The following is a description of a gene set: species: Homo sapiens Human Gene Set: GOBP_MUSCLE_TISSUE_DEVELOPMENT The progression of muscle tissue over time, from its initial formation to its mature state. Muscle tissue is a contractile tissue made up of actin and myosin fibers., and this is the list of marker genes: MSTN, MYOM1 (NCBI Gene Id 8736), CCNT2, ABL1, CDK1, BCL9L, MIR548C, ITGB1, GREB1L, FGF8, KLF5, FGF20, MYL6, MEF2A, PPP3CB, ZMPSTE24, TTN, EFEMP2, POGLUT1, LUC7L, FOXP2, ALPK3, BVES, PIM1, TSC1, NPR2, LEMD2, MIR19B1, GSK3A, EP300, MYOCD, KAT8, TGFB1 (NCBI Gene Id 7040), MYF6, NPPB, PLEC, SMAD4, JPH2, KDM6B, MIR19A, PRKG1, TGFBR3, COL14A1, SOX6, FHL2, GPX1 (NCBI Gene Id 2876), FOS, NPRL3, FKBP1A, PROX1, FOXN2, CAV3, FGF2, CCNB1 (NCBI Gene Id 891), CHRND, MIR23A, KRAS, PITX2, GREM1, CSRP3, ADAMTS9, MCUB, MSX2, VGLL4, ZFPM1, ALPK2, MBD2, MYOZ2, ATG5, ISL1, MED1, EGLN1, AKAP13, RXRB, MEF2C, PPP1R13L, CDK5, PKD2 (polycystin 2, transient receptor potential cation channel), TCAP, CHRNA1, CALR, FGFR2, SVIL (NCBI Gene Id 6840), TREX1, MIR24-1, ATF3, KCNJ8, BARX2, KEL, DMRTA2, MYH15, NOG, NOX4, NOTCH2, FGFR1, HMG20B, HLF, NR2F2, CACNA1G, KLHL40, PAX7, FZD7, MYOZ1, MIR208A, PAX5, FLOT1 (NCBI Gene Id 10211), MYH14, VAMP5, SELENON, TBX5, MIR222, IGF2, TCF21, MYL11, CNTNAP1, FGF9, COL11A1, DDX5, WNT10B (NCBI Gene Id 82499), IFRD1, RBM24 (RNA binding motif protein 24), MIR1-1, FRS2, MSC, GLI1, PRMT1, WNT3A, HSD17B1, MYORG, SMAD1, RYR1, FOSL2, VAX1, MAPK14 (mitogen-activated protein kinase 14), NUPR1, TENM4, AKAP6, RHOA, CACYBP (calcyclin binding protein, NCBI Gene Id 27101), TNNI1, PHOX2B, TLL2, MIR195, PGM5, BMPR1A, PAK1 (p21 (RAC1) activated kinase 1), ACTA1, HLX, SLC8A1, RARB, ADRA1A, RBP4, NR4A1, EDNRA, ACTC1, RYR2, YY1, MYLK3, MIR873, G6PD, UQCC2, TBX2, GATA4, RGS4, BMPR2, MYBPC3, MYLK2, MIR145, TBX18, NOTCH1, WT1, CASQ1, MYO18B, COPS2, ACVR1, MYL6B, TGFB2, DSP, CHD7, MYC, SOX8 (SRY-box transcription factor 8), IRX3, HEY1, PI16, OSR1, B4GALNT2, HAND1, SKIL, SKI, MIR509-1, SGCD, DNER, VEGFA, FOXL2, HOXD10, NR1D2, TIPARP, MIR143, MYF5, CTNNB1, MYLK, MED20, PDLIM5, ERBB4, PARP2, RBPJ, MIR204, CAV2, PLN, FOXC1, ASB2, COL6A1, SHH, ANKRD1, GATA5, STRA6, NKX2-5, LRRC10, CDC42, CENPF, NDRG4, SGCG, MYH6, MYL2, EYA2, KCNJ11, ANHX, MYH11, NAGLU, CYP26B1, PKP2, POPDC3 (popeye domain containing 3), CTDP1, DMD, BCL2, ABCC9, CTCF, CACNA1S, SGCZ, TPM1 (tropomyosin 1), PPP3CA, DDX17, HEG1, YBX3, EFNB2, CREB1, CDON, HCN4, RARA, SAP30, MTPN, SIK1, SORBS2, HEYL, IFT20, SIRT6, MYOM2, PDGFRB, IGSF8, GJB6, COL19A1, MIR199A1, TOMM70, MYOD1, ACADM, MSX1, BMP4, MIR17HG, MYOG, NEURL1, MEIS1, NPPA (natriuretic peptide A), XIRP2, FGF3, SEMA3C, MIR499A, CFL2, CFLAR, EDN1, MTM1, ERBB3, SIX4, PTCD2, CBY1, CSRP2, EOMES, NEBL, DLL4, DLL1, RPL3L, HOPX, TGFBR1, NLN, HEY2, MBD3, METTL21C, KCNK2, SMAD3, MIR25, MEGF10, PITX1, NEB, CAV1, PDGFRA, XK, ID2, BIN3, TNNI3, NACA, TBX3, POPDC2, TWIST1, KLHL41 (NCBI Gene Id 10324), SIX1, IHH, CXADR, MIR199B, MRTFB, UBE4B, CITED2, MEOX2, LRP2, POU4F1, IGFBP5, HDAC9, ELN, ENG, MIR200B, DIPK2A (divergent protein kinase domain 2A), SOX15, C10orf71, STAC3, MIR590, S1PR1, MESP1, FKTN, SMAD7, VRK3, S100B, SCN5A, SMAD5, EGR2 (early growth response 2), ARRB2, JARID2, GJA1, NKX2-6, ITGA8, TFAP2B, HNRNPU, PRKAA1, HIVEP3, ERO1A, ASNSD1, SOX11, HOXD9, GJC1, FHOD3, ACTN3, PRKAR1A, SCX, TNNT2, DKK1, EEF2, COL3A1, BTG2, ACTN2, MYL7, PTCH1, NRG1, BMP10, SMO, MTOR, P2RX2, LARGE1, IGF1, TBX1 (T-box transcription factor 1), SAV1, DSG2, FLNB, SMYD1, BMAL1, PPIF, ANKRD33, GATA6, TNN, TNNC1, PPARA, YAP1, GTF3C5, LEF1, TP73, MYH7, SRPK3, ZIC3, SLC9A1, ZFAND5, FOXC2, EPHB1, ZBTB18, ARID2, FKRP, GPC1, HDAC3, CSRP1, AKIRIN1, LOX, SIRT2, ZFPM2, ALDH1A2, KAT2A, FOXP1, FOXH1, MAFF, PRICKLE1, NDUFV2, TBX20, OBSL1, BCL9, RB1, EGR1, FBXO22, NRAP, USP19, SRF, GJA5 (gap junction protein alpha 5), NPHS1, SOX9, NF1, HOMER1, GPCPD1, SGCB, FES, MYL3, RGS2, MAML1, BMP7, ZNF689, EYA1, ADPRHL1, VGLL2, VPS54, BMP5, MYH10, LMOD3, EMD, SPG11, WNT2, LMNA, DLG1, BMP2, RUNX1, MAPK11, SHOX2, RCAN1